Given this list of marker genes TM4SF1, C16orf54, KLK6 (NCBI Gene Id 5653), RGS17, S100G, MYOD1, LYPD8, DYSF, SLC6A2, ADH7, LGALS9, PTGES, MMP13, G0S2, GPR15LG, TAGLN, RBP1, SCGB1A1, S100A5, CSTA, RBP7, CCL7 (NCBI Gene Id 6354), ANKRD1, ZCCHC18, GYS2, CCND2, DPEP2, IFITM1, EBF1, SPARC, CCDC68, HEPH, CALCB, KLK8, CRCT1, CYP1A1, GAS6, PLAC8, MCUB, OPTN, HSPA2, TRPV2 (NCBI Gene Id 51393), CLDN18, IGFBP5, MMP10, ACKR3 (NCBI Gene Id 57007), GPNMB, TFPI, FUNDC2, OCM (NCBI Gene Id 91268), SERPINE1, MMP7, CES2, SPP1, AMN1, COL1A1, S100A8, CLDN6, FCER2, SLC34A2, AEBP1, IL17RD, SYT16, AQP8, PRAF2, NNAT, here is a description of the gene set: Human Gene Set: YAMASHITA_METHYLATED_IN_PROSTATE_CANCER To identify methylation-silenced genes in prostate cancers, a microarray analysis for genes up-regulated by treatment with a demethylating agent, 5-aza-2'-deoxycytidine, was performed using three rat prostate cancer cell lines. Eight genes (Aebp1, Dysf, Gas6, LOC361288, Nnat, Ocm, RGD1308119, and Tgfbr2) were re-expressed at 16-fold or more, and their promoter CpG islands were shown to be densely methylated in the cancer cell lines. From the eight genes, Tgfbr2, a key mediator of transforming growth factor-beta (TGF-beta) signaling that has been strongly implicated in human and rat prostate carcinogenesis, was selected, and its silencing in primary samples was analyzed further. Tgfbr2 was methylated and markedly down-regulated in three of seven 3,2'-dimethyl-4-aminobiphenyl-induced invasive adenocarcinomas in the dorsolateral lobe of the rat prostate. In humans, marked down-regulation of TGFBR2 protein was observed in 12 of 20 high-grade prostatic intraepithelial neoplasia and 36 of 60 prostate cancers. DNA methylation of the human TGFBR2 promoter CpG islands repressed transcription, if present, but neither methylation nor mutation were detected in 27 human prostate cancers analyzed. Methylation silencing of rat Tgfbr2 was associated with histone H3 lysine 9 trimethylation, whereas decreased expression of human TGFBR2 was mainly due to decreased transcription activity, sometimes in concert with histone deacetylation and H3 lysine 27 trimethylation. The identification of methylation silencing of Tgfbr2 in rat prostate cancers, in accordance with TGFBR2 down-regulation in human prostate cancers, will enable us to analyze how aberrant methylation is induced in vivo and identify factors that promote and suppress the induction of aberrant methylation. from publication Yamashita S, Takahashi S, McDonell N, Watanabe N, Niwa T, Hosoya K, Tsujino Y, Shirai T, Ushijima T (PMID 18381416) Genes up-regulated in prostate cancer cell lines after treatment with 5-aza-2'-deoxycytidine (decitabine). studied in species Rattus norvegicus